Given this list of marker genes DNMT3A, GSK3A, DNMT3L, PIK3CA, MYCN, ZFP57, here is a description of the gene set: studied in species Homo sapiens The establishment of epigenetic modifications (imprints) in autosomal (non-sexual) chromosomes during gametogenesis, and propagation of these imprints during the organism's life. Genomic imprinting leads to an asymmetry between the maternal and paternal alleles and differential expression of the corresponding alleles. This can happen through heterochromatin formation or differential chromatin loop formation. Human Gene Set: GOBP_AUTOSOME_GENOMIC_IMPRINTING